Given this list of marker genes GAP43, NEO1, EOLA1, IGDCC4, SEMA4A, PCDHA13, PCDHA7, ATP2B1, KCNJ2, ETS1 (NCBI Gene Id 2113), PCDHA12, SMC1B, DENND10, ZNF558, SIX4, THAP2, LPAR2, CHKA, AKT3 (NCBI Gene Id 26068), PCDHA6, PCDHA2, TRAF3, DCAF8, PCDHA10, KRTAP26-1, ZNF570, KIAA1210, ADAM12, TSHZ3, CHD7, PCDHA1, CD300LD-AS1, EIF4E3, ADGRB2, C10orf67, PCDHA4, PEBP1, DYNC2LI1, MAPK10, NTRK2, PCDHA8, MDC1, CLVS2, SPRYD7 (NCBI Gene Id 65073), SOX21, TMPO, PCDHA3, PCDHA11, RNASE13, MAGEA8, PAFAH1B1, NFIB, PCDHAC1, KCTD9, NOTCH3, MALL, RPRD1A, CHEK2, SOCS7, MAGEA1, NFIL3, LRAT, INSR, PCDHA5, PCDHAC2, PCDHA9, FAM168A, CADPS, OGDH, UBL3, OSBPL6, here is a description of the gene set: from publication Chen Y, Wang X (PMID 31504780) Genes predicted to be targets of miRBase v22 microRNA hsa-miR-759 in miRDB v6.0 with MirTarget v4 prediction scores > 80 (high confidence targets). Human Gene Set: MIR759 studied in species Homo sapiens